Given this list of marker genes Eri1, Rexo1, Exosc10, Exosc8, Exosc2, Rps21, Exosc9, Exosc3, Rexo5 (RNA exonuclease 5), Exosc7, here is a description of the gene set: studied in species Mus musculus Mouse Gene Set: GOBP_RRNA_3_END_PROCESSING Any process involved in forming the mature 3' end of an rRNA molecule.